Given this list of marker genes PCK2 (NCBI Gene Id 5106), LSP1P4, ADAMTS1, MT1H, NET1, RAB11B, WNT5A, ATOX1, RABGGTB, DSCAM, MPP3, ADH6, SSR3, CYB5A, PDGFRL, IFNGR2, CYBRD1, FBLN2, MOK, ID1, PDCD2, RUFY3, CYP51A1 (NCBI Gene Id 1595), HSPB8, ESD, IL16, PPA1, POLR2F, CD36, ITGB5, ATF7, ASMTL, RHOBTB3, ABCC1, USP9X, ANKRD11, here is a description of the gene set: species: Homo sapiens The accumulation of DNA damage and mutations is considered a major cause of cancer and aging. While it is known that DNA damage can affect changes in gene expression, transcriptional regulation after DNA damage is poorly understood. We characterized the expression of genes in human primary fibroblasts after exposure to three different kinds of cellular stress that introduces DNA damage: 4-nitroquinoline-1-oxide (4NQO), gamma-irradiation, or UV-irradiation. Each type of stress elicited damage specific gene expression changes of up to 10-fold. A total of genes had similar changes in expression of 3-40-fold after all three kinds of stress. We examined transcription in cells from young and old individuals and from patients with Werner syndrome (WS), a segmental progeroid condition with a high incidence of cancer, and found various age-associated transcriptional changes depending upon the type of cellular stress. Compared to young individuals, both WS and old individuals had similarly aberrant transcriptional responses to gamma- and UV-irradiation, suggesting a role for Werner protein in stress-induced gene expression. Our results suggest that aberrant DNA damage-induced gene regulation may contribute to the aging process and the premature aging in WS. from publication Kyng KJ, May A, Stevnsner T, Becker KG, Kølvrå S, Bohr VA (PMID 15897889) Human Gene Set: KYNG_DNA_DAMAGE_BY_4NQO Genes specifically responding to 4NQO treatment of primary fibroblasts.